Given this list of marker genes CROCC, CEP44, NIN (ninein), CEP68, CEP250, CEP135, CNTLN, CTNNB1, ODF2, KIF3A (kinesin family member 3A), DCTN1, RTTN, CCDC102B, SGO1, NEK2, here is a description of the gene set: The cell cycle process in which the two centrioles within a centrosome remain tightly paired. studied in species Homo sapiens Human Gene Set: GOBP_CENTRIOLE_CENTRIOLE_COHESION